Given this list of marker genes CENPX, FANCA, FAAP20, FANCM, FANCB (NCBI Gene Id 2187), FANCC, FAAP24, FANCG, FANCF, FAAP100, CENPS, FANCL, FANCE, here is a description of the gene set: Human Gene Set: GOCC_FANCONI_ANAEMIA_NUCLEAR_COMPLEX species: Homo sapiens A protein complex composed of the Fanconi anaemia (FA) proteins including A, C, E, G and F (FANCA-F). Functions in the activation of the downstream protein FANCD2 by monoubiquitylation, and is essential for protection against chromosome breakage.